The following is a description of a gene set: The process in which a microtubule is broken down into smaller segments. Severing enzymes remove dimers from the middle of the filament to create new ends, unlike depolymerizing kinesins that use ATP to uncap microtubules at their ends. Human Gene Set: GOBP_MICROTUBULE_SEVERING species: Homo sapiens, and this is the list of marker genes: KATNB1, KATNA1, TTLL6, KATNAL1, TTLL11, FIGNL2 (NCBI Gene Id 401720), SPAST, KATNAL2, LZTS2